The following is a description of a gene set: Human Gene Set: HP_CHRONIC_BRONCHITIS Chronic bronchitis species: Homo sapiens Chronic inflammation of the bronchi., and this is the list of marker genes: POLD1, ZBTB24, ODAD2, DNAAF4 (dynein axonemal assembly factor 4), SCNN1A, UBAP2L, CCDC65, SERPINA1, CARMIL2, CCDC40, ZMYND10, CFAP298, TAP2, SPAG1, DNAAF11, CFTR, CCDC39, RAC2, DNAH7, DNAAF5, ALMS1, SCNN1G, ODAD3, SCNN1B, TRAF3IP1, DNMT3B, GUSB, RSPH4A, HYDIN